Given this list of marker genes Tsc2, Usp36, Lzts1, Tspo, Hdac6, Vps13c, Htra2, Tmem39a, Smcr8, Lypla1, Phf23, Fez1, Clec16a, Trp53, Ubqln4 (ubiquilin 4), Nrbp2, Becn1, Qsox1, Hmox1, Nupr1 (nuclear protein transcription regulator 1), Pptc7, Scfd1, Fez2, Rubcn, Sec22b, Tsc1, Lrrk2, Ehmt2, Mtor, Usp30, Pink1, Rnf41, Tigar, Poldip2, Mtm1, Fbxl4, Npc1, here is a description of the gene set: species: Mus musculus Mouse Gene Set: GOBP_NEGATIVE_REGULATION_OF_MACROAUTOPHAGY Any process that stops, prevents, or reduces the frequency, rate or extent of macroautophagy.